The following is a description of a gene set: Dengue-2 interactions with complement and coagulation cascades Human Gene Set: WP_DENGUE2_INTERACTIONS_WITH_COMPLEMENT_AND_COAGULATION_CASCADES species: Homo sapiens, and this is the list of marker genes: C6, BDKRB1, CFI, SERPINE1, C3AR1, CFH, MASP1, CFB, PROS1, F5, CD55, SERPINC1, F2R, KLKB1 (NCBI Gene Id 3818), CR1, PLAUR, C1R, C8G, SERPINF2, CR2, C1QA (NCBI Gene Id 712), CPB2 (NCBI Gene Id 81954), C2, FGB, TFPI, PLAU, C9, F8, CLU, SERPINA5, C4B, THBD, SERPING1, PLG, MASP2, F10, VWF, F12, F2, CFD, F9, C5AR1, C3, SERPINA1, APOA2, CD46, C7, F3, CLTC, KNG1, LMAN1, C1QB, PLAT (NCBI Gene Id 5327), C1QC, C1S, F13B, SERPIND1, F7, PROC